Given this list of marker genes PEX3, DPP6, POMGNT2, FBN2, ADAMTS18, ACTB, HHAT, SAG, CNGB3, PEX14, PEX1 (NCBI Gene Id 7788), TUBGCP6, MAFB, ROM1, ELOVL4, POMT1, PEX10, PEX26, RPE65, POMK, COL4A1, OCRL, SHH, TUBGCP4, TCTN2, CFI, MAGEL2, DCT, LCA5, ACVRL1, SEMA3E, KRIT1, GUCA1A, IFNG, EFEMP1, VSX1, CYP4V2, COL8A2, SIM1, WAC, FZD5, CLCNKB, APOE, CHM, DACT1, CHN1, POMT2, RPGRIP1L, PIK3CA, HADHA, OVOL2, MICOS13, ABCA4, CHD7, SPTBN1, RPGRIP1, CRPPA, NDE1, ZNF408, HLA-A, WT1, CSPP1, NRL, PAX2, B9D1, TIMP3 (NCBI Gene Id 7078), HMX1, XYLT2, KIF11, LARGE1, RERE, SALL4, FKTN, XYLT1, HCCS, RBP4, PORCN (NCBI Gene Id 65017), BMP4, PEX19, C1QTNF5, JAG1 (jagged canonical Notch ligand 1), B9D2, PEX11B, NDP, TMEM216, ABCB6 (ATP binding cassette subfamily B member 6 (LAN blood group)), MKS1, BCOR, CLEC3B, FBLN5, CRX, SLC25A15, RAX, NF1, CCM2, CFHR3, UBE3B, PRPH2, POU3F4, TSPAN12, NAA10, RNU7-1, RP2, B4GAT1, GRHL2, MPDZ, LRP5, PAX6, HMCN1, SALL1, B3GALNT2, TCTN3, CFH, TEAD1, HMGB3, COL9A1, TMEM107, FSCN2, PEX5, CLDN19, CRB1, KRAS, ZNF668, FBLN1, ALDH1A3 (aldehyde dehydrogenase 1 family member A3), CTNNB1, DHX16, OAT (ornithine aminotransferase), GDF3, GZF1, ZEB1, VPS13B, GNAQ, POMGNT1 (NCBI Gene Id 55624), ZNF423, ENPP1, PRSS56, FKRP, AGXT, PEX12, IKBKG, GUCY2D, SIX3, PTPN22, TSC2, C12orf57 (chromosome 12 open reading frame 57), PNPLA6, IMPG1, PEX13, INPP5E, MFRP, RLBP1, MAX, PIGL, VPS35L, CDH3, TSC1, TMEM237, OTX2, COL18A1, CC2D2A, NDUFB11, VPS33A, EPHA2, TCTN1, WASHC5, LRAT, SIX6, NOD2, TBX22, SPATA7, ZEB2 (NCBI Gene Id 9839), FZD4, TMEM98, TMEM67, TMEM231, MAPKAPK3, HLA-DRB1, AKT1, DPYSL5, PDCD10, BEST1, RXYLT1, EYS, FAS, CCDC22, COX7B, CLCN2, PEX2, CEP290, TMEM138, VCAN, ABCC6, PROM1, IMPG2, PEX16, CFHR1, YAP1, SOX2, PEX6, DAG1, TXNDC15, here is a description of the gene set: Any structural abnormality of the choroid. Abnormal choroid morphology studied in species Homo sapiens Human Gene Set: HP_ABNORMAL_CHOROID_MORPHOLOGY